Given this list of marker genes Naxe, Nudt12, Naxd, Naprt, Nampt, Slc22a13, Slc5a8, Rnls, Nnmt, here is a description of the gene set: Mouse Gene Set: REACTOME_NICOTINAMIDE_SALVAGE Nicotinamide salvage species: Mus musculus